The following is a description of a gene set: Abnormality of the Achilles tendon species: Homo sapiens An abnormality of the Achilles tendon. Human Gene Set: HP_ABNORMALITY_OF_THE_ACHILLES_TENDON, and this is the list of marker genes: COL12A1, SLC12A6, HINT1, FKTN, GNS, CRPPA (CDP-L-ribitol pyrophosphorylase A), TTN, PLAAT3, MT-TE, OPA1, POMT1, BICD2 (BICD cargo adaptor 2), SLC39A14, POU3F4, ADAMTS15, HRAS, NSUN2 (NCBI Gene Id 54888), UFC1, ABHD12, EMD, TMEM43, SLC25A4, DMD, KY, LMX1B, SYNE1, SPTAN1, MARS1, ABCC9, COL6A2, MTMR14, JAG2, ZC4H2, MEGF10, SYNE2 (NCBI Gene Id 26075), TNNT1, NGLY1, PLEC, MYOT, ADAT3, FKRP, ACTA1, SGCA, CYP27A1, PYROXD1, ARL6IP1, TFG, KL, COL6A3, DNM2, FHL1, SCN4A, ALS2, LMNA, HGD, PRKCG, GJB1, SGCG, KRT1, LARGE1, PTRH2, GAN, COL6A1, WRN